Given this list of marker genes AP3M2, TRAK2, BLOC1S3, CDC42, MAP1B, UCHL1, LAMP1, SYBU, KIF16B, DTNBP1, RHOT1, SYNE2, HSBP1, TRIM58, UBB, SNAPIN, BICDL1, RHOT2, HIF1A, SPAST, KIF3A, TRAK1, KIF5B, BLOC1S6, PAFAH1B1, COPG2, CDR2L, MAPT, HDAC6, AP3M1, UXT, RASGRP1, KIFAP3, BLOC1S1, AP3S1, AP3S2, AP3B2, AGBL4, NDE1, BICD1, FEZ1, COPG1, BICD2, WASF1, KIF28P, CLN3, BORCS7, ARMCX3, KIFBP, BLOC1S4, KIF1C, NEFL, SUN1, RAB1A, TRIM46, STK11, KIF1A, BORCS6, SPG11, MAP1S, BLOC1S2, MGARP, MAP2K1, KIF13A, SUN2, ARHGAP21, AGTPBP1, BLOC1S5 (biogenesis of lysosomal organelles complex 1 subunit 5), KXD1, KIF3B, OPA1, BORCS8, NDEL1, RAB6A, HTT, ACTR10, MAP2, AP3B1, FYCO1, FBXW11, BORCS5, BICDL2, KIF5A, TUBA1A, HAP1, LRPPRC, MREG, AP3D1 (adaptor related protein complex 3 subunit delta 1), TMEM201, PEX14, DYNC1I1, NEFH, KIF1B, here is a description of the gene set: Human Gene Set: GOBP_ORGANELLE_TRANSPORT_ALONG_MICROTUBULE The directed movement of an organelle along a microtubule, mediated by motor proteins. This process begins with the attachment of an organelle to a microtubule, and ends when the organelle reaches its final destination. species: Homo sapiens